The following is a description of a gene set: Reactome Pathway: APC/C:Cdc20 mediated degradation of mitotic proteins electronically inferred by orthology from the curated human pathway studied in species Mus musculus part of: Activation of APC/C and APC/C:Cdc20 mediated degradation of mitotic proteins This event has been computationally inferred from an event that has been demonstrated in another species.<p>The inference is based on the homology mapping from PANTHER. Briefly, reactions for which all involved PhysicalEntities (in input, output and catalyst) have a mapped orthologue/paralogue (for complexes at least 75% of components must have a mapping) are inferred to the other species., and this is the list of marker genes: Psmc1, Cdk1, Cdc26, Ube2s, Ccna1, Psma4, Psma3, Anapc2, Psmb4, Psmb6, Ube2d1, Psmc5, Psmd1, Mad2l1, Psmc2, Psmb7, Ube2c, Anapc15, Psmb5, Psmc4, Anapc7, Anapc10, Psma5, Ube2e1, Ccnb1, Psma6, Rps27a, Psma1, Cdc23, Psmd13, Ubb, Psmd12, Psmc6, Psma2, Psmd6, Psmc3, Psma7 (proteasome subunit alpha 7), Psmd7